The following is a description of a gene set: from publication Durante MA, Kurtenbach S, Sargi ZB, Harbour JW, Choi R, Kurtenbach S, Goss GM, Matsunami H, Goldstein BJ (PMID 32066986) Human Gene Set: DURANTE_ADULT_OLFACTORY_NEUROEPITHELIUM_PERICYTES studied in species Homo sapiens, and this is the list of marker genes: PECAM1, KLF2, KCTD12, PODXL, RDX, TM4SF18, PALMD, CRIP2, SOX17, APOLD1, IFI27, THBD, VWF, TMEM88, CCDC85B, ENG, CLEC14A, TSPAN7, HLA-E, FAM13C, PLVAP, FXYD5, TIMP3, TXNIP, LIFR, ID3, CD34, FLT1, ESAM, NPDC1, LPAR6, ABCB1, CXCL12, CAVIN2, SELE, C2CD4B, TM4SF1, CLU, SPTBN1, CD93, ABCG2, GNG11, RAMP2, EMP1, GIMAP7, RUNDC3B, CD74, PRCP, CYYR1, JAM2, EMCN, PCAT19, TCF4, CLDN5, SOX18, ITM2A, VIM, EDN1, IGFBP4, NOSTRIN (NCBI Gene Id 115677), EGFL7, RAMP3, CDKN1A, CAV1, NHERF2 (NCBI Gene Id 9351), SPARCL1, PLAT, ECSCR, SOCS3, LMCD1, SPRY1, AQP1, A2M, ACKR1, CALCRL, TGFBR2, ADGRL4, FAM110D, CAVIN1 (NCBI Gene Id 284119)